The following is a description of a gene set: Human Gene Set: KEGG_MEDICUS_REFERENCE_BCR_BCAP_CD19_PI3K_SIGNALING_PATHWAY species: Homo sapiens BCR-BCAP/CD19-PI3K signaling pathway. Pathway ID: N01695. Pathway type: Reference. Pathway class: nt06530 PI3K signaling. Pathway Definition from KEGG: IGH -> (LYN,SYK) -> (PIK3AP1,(CD19+CD21+CD81+IFITM1)) -> PI3Kdelta -> PIP3 -> AKT, and this is the list of marker genes: LYN, CD19, PIK3AP1, ENSG00000275063, AKT3, PIK3CD, IFITM1, CD81, PIK3R1 (NCBI Gene Id 5295), PIK3R2 (NCBI Gene Id 5296), AKT1, PIK3R3, AKT2, SYK, CR2